Given this list of marker genes P2ry2, Gpr17, Lpar4, P2ry13 (purinergic receptor P2Y, G-protein coupled 13), P2ry1, Adora2a, P2ry4, P2ry10, Lpar6, here is a description of the gene set: This event has been computationally inferred from an event that has been demonstrated in another species.<p>The inference is based on the homology mapping from PANTHER. Briefly, reactions for which all involved PhysicalEntities (in input, output and catalyst) have a mapped orthologue/paralogue (for complexes at least 75% of components must have a mapping) are inferred to the other species. Reactome Pathway: Nucleotide-like (purinergic) receptors part of: Class A/1 (Rhodopsin-like receptors) species: Mus musculus electronically inferred by orthology from the curated human pathway